The following is a description of a gene set: Human Gene Set: BLALOCK_ALZHEIMERS_DISEASE_INCIPIENT_UP The pathogenesis of incipient Alzheimer's disease (AD) has been resistant to analysis because of the complexity of AD and the overlap of its early-stage markers with normal aging. Gene microarrays provide new tools for addressing complexity because they allow overviews of the simultaneous activity of multiple cellular pathways. However, microarray data interpretation is often hindered by low statistical power, high false positives or false negatives, and by uncertain relevance to functional endpoints. Here, we analyzed hippocampal gene expression of nine control and 22 AD subjects of varying severity on 31 separate microarrays. We then tested the correlation of each gene's expression with MiniMental Status Examination (MMSE) and neurofibrillary tangle (NFT) scores across all 31 subjects regardless of diagnosis. These well powered tests revealed a major transcriptional response comprising thousands of genes significantly correlated with AD markers. Several hundred of these genes were also correlated with AD markers across only control and incipient AD subjects (MMSE > 20). Biological process categories associated with incipient AD-correlated genes were identified statistically (ease program) and revealed up-regulation of many transcription factor/signaling genes regulating proliferation and differentiation, including tumor suppressors, oligodendrocyte growth factors, and protein kinase A modulators. In addition, up-regulation of adhesion, apoptosis, lipid metabolism, and initial inflammation processes occurred, and down-regulation of protein folding/metabolism/transport and some energy metabolism and signaling pathways took place. These findings suggest a new model of AD pathogenesis in which a genomically orchestrated up-regulation of tumor suppressor-mediated differentiation and involution processes induces the spread of pathology along myelinated axons. Genes up-regulated in patients at the incipient stage of Alzheimer's disease. studied in species Homo sapiens from publication Blalock EM, Geddes JW, Chen KC, Porter NM, Markesbery WR, Landfield PW (PMID 14769913), and this is the list of marker genes: CDC42EP4, NUP98, USP19, CYP11A1, IL10RA, TNFRSF11B, GOLGA4, HNRNPUL1, QARS1 (NCBI Gene Id 5859), PPP1R13L, FLII (FLII actin remodeling protein), TSC22D4, GTF2I, PI4KB, SRPK2, TCF3, MATN2, MT1F, NFIC (nuclear factor I C), IPP, DAPK2, NBAS, ZNF253, BGN, LIMK2, RHOQ, ARID4A, SPIB, GTF2H3, PBRM1, ERAL1, AGTR1, NONO, FUT2, RAB2A, SYNC, PRCP, DPF3, JRK, PRL, CLDN5, NCOA3, PRPF40A, ZNF350, CSDE1, FBN1, ZHX3, ERLIN2, SLC35A3, CRYBG1 (crystallin beta-gamma domain containing 1), TPD52, LAMA4, CTSS, TNS3, EWSR1, ARID1A, CAST, CTDSP2, ATG3, TLR1, RABEP1, RUNX2, AGFG2, NAMPT, PGAP6, KLF2, SLC14A1, CSNK2A2, EPS8, USH1C, FBXW4P1, PSG3, ZFP36L2, PTGIS, KTN1, GJA1, GDF1, PXN, RAB1B, PML, IFT74, IFNA5, IL18, CLIC1, NT5C, COG4, GOSR2, STAG2, TBXA2R, PAH, IL2RG, ADGRA3, RNASET2, TUBD1, ITGA1, PTBP3, SLC35C1 (NCBI Gene Id 55343), PLD2, CYP4F3, SAP30BP, HOXC4, CNPY3 (NCBI Gene Id 10695), TENT5A, AKAP9, JAK3, KLHL20, MDM1, PLAG1 (NCBI Gene Id 7996), NMB, SEMA3B, GAMT, CPNE3, AGO1, CR1, ITGA7, SLC19A1, FAM3A, ANGPTL2, SNX11, S100A4, IL17RA, SLC35F2, APOL2, RBBP5, DAO, PI4K2A (NCBI Gene Id 55361), FBN2, TEX264, PCDH11X, FYN, SEC63, EMID1, RAD1, CD58, RHBDD3, SSH3, ADCY7 (adenylate cyclase 7), MAB21L2, TACC1, SNHG20, ZNF24 (zinc finger protein 24), MBP, ZNF43, ATP8B1, ARFGAP2, ERBIN, CFLAR, ITGA6, TBC1D5, ZNF444, OASL, TNFRSF9, OGG1, SP3, SSR2, ALMS1, RNGTT, ZNF160, GNAI3, INPP5K, GABRQ (NCBI Gene Id 55879), MALT1, ZNF268, ST6GALNAC4, TOPORS, DCN, RBM8A, PER1 (NCBI Gene Id 5187), TASOR, SYF2, GTF2H1, LEF1, CALML4, ZNF136, PHF20, OSBPL11, SLC12A3, TCOF1, KDSR, ZNF544, ITPRID2, ARHGEF15, PPIG, GNAZ, ZBTB10, CPSF1, EFEMP1, FZR1, JUND, CTPS2, DMC1, TTN, APLNR, SMARCC2, CPQ, FBXW4, APOC4, ZMYM5, LPAR4, GMPR, PLOD2, FADS1, TM7SF3, KAT2B, ISLR, GSK3B, GIPC1, LARP7, KCNJ14, TNC, HLA-DPA1, SNRK, GLI2, SFRP1, TGFBR3, NUCKS1, HAO2, FNBP1, MR1, CLU, MET, IFNG (interferon gamma), ATP10D, SMARCC1, CCDC59, WWP2, ZMYM2, HERC5 (NCBI Gene Id 51191), ESS2, ARFGAP1, RBL1, SSPN, BRD1, PTH1R, FGFR3, MLANA, ENAH, TSR3, TCN2, CDC5L, MARCHF6, MFAP1, H2AZ2, ZNF7, PRP4K, FGL1, ERAP1, NUMA1, IL13RA1, EP300, NEBL, PGM3, ACTR8, PDCL, ARHGAP17, SERTAD3, PDSS1, TTTY9A, GPR107 (NCBI Gene Id 85011), IKZF4, AKAP13, ADD3, CUL4A, LAMA2, MED1, SREBF1, SLAMF1, ZNF84, PDE4C, RGS9, BRAP, H2AJ, GPSM3, CLDN18, VRK3, RBCK1, ZNF83, DARS1 (NCBI Gene Id 1615), EDNRA, IL10RB, SPAG1, TNXA, DIP2A, HS2ST1, PDGFB, CEBPA, DLX4, FLNC, LSM5, ID4, POLH, ENOSF1, CDC14A, TSPAN31, DBF4, PC, IL6R, PABPC3, ZNF254, H3-3B, UGT1A10, MYO1A, F2R (NCBI Gene Id 2149), EIF5B, QKI, CPT2, VCAN, C5, ZNF32, RBPJ, TRIM44, LUC7L3, RNASEH2A, TAX1BP3, CTDSP1, GBP1, COL8A2, EIF2AK2, CDK2AP1, CTRC, DICER1, CEP350 (NCBI Gene Id 9857), APP, CD44, RBBP6, PSMC3IP, SNX16, BRS3, TP53AIP1, MYO10, NKTR (natural killer cell triggering receptor), NPAS3, FAXDC2 (NCBI Gene Id 91674), GGCX, POLR1B, SGK1, HMGB3, OS9, GRM6, NCAPD2, CYP39A1, CASP6, NOTCH4, SYCP2, WWTR1, THOC2, PIBF1, CPM, USP1, CHD2 (NCBI Gene Id 283680), KCNK10, RPL13, SCLY, CTSL, ARPC1B, SMC1A, ERF, NCAPG, PRKAR2A, DGCR6, SFN, NEK7, RXRB, EFEMP2, ANGPT1, CSF1, PGLS, COTL1, NSDHL, NAP1L1, TRIM38, PLXNB2, TAOK2 (TAO kinase 2), NDST1, MRM3, TRMT1L (NCBI Gene Id 81627), UROD, SSH1, LAMC1 (NCBI Gene Id 3915), ASCL1, YES1, ANP32B, SGK2, ZC3H7B, PRDX6, WAS, HOXB5, APOC1, PTGS1